The following is a description of a gene set: from publication Chen Y, Wang X (PMID 31504780) studied in species Mus musculus Mouse Gene Set: MIR_139_3P Genes predicted to be targets of miRBase v22 microRNA mmu_miR_139_3p in miRDB v6.0 with MirTarget v4 prediction scores > 80 (high confidence targets)., and this is the list of marker genes: Camk1d, Pvr, Elk1, Sema6a, Banp, Rbm26, Gpr107, Pdgfc, Aak1 (AP2 associated kinase 1), Mcrs1, Cxcl16, Thap11, Twist2, Csnk2a1, Col6a3, Tmem72